Given this list of marker genes APOD, SOCS5, GSTP1 (glutathione S-transferase pi 1), C1QTNF3, NR1H4 (nuclear receptor subfamily 1 group H member 4), ERBIN, here is a description of the gene set: studied in species Homo sapiens Any process that stops, prevents, or reduces the frequency, rate, or extent of production of monocyte chemotactic protein-1. Human Gene Set: GOBP_NEGATIVE_REGULATION_OF_MONOCYTE_CHEMOTACTIC_PROTEIN_1_PRODUCTION